Given this list of marker genes PCLAF, HMGN2, AURKB, BIRC5, HMGA1, ANP32E, KPNA2, DUT, GAPDH, CDK1, H4C3, SMC4, ZWINT, TUBA1B, HMGB2, SNRPF, RAN, NUSAP1, RANBP1, LDHA (lactate dehydrogenase A), SNRPD1, CKS1B, STMN1, CENPM, PTTG1, ANP32B, H2AZ2, UBE2C, MCM7, MKI67, ENO1, CDKN3, TK1 (NCBI Gene Id 7083), PCNA, DEK (NCBI Gene Id 7913), TUBB, TUBB4B, H2AZ1, TYMS, CKS2, TOP2A, HMGB1, RRM2, PKM, TCL1A, IRAG2, SLC25A5, here is a description of the gene set: Genes upregulated in subsets of cells of a given type within various tumors from publication Gavish A, Tyler M, Greenwald AC, Hoefflin R, Simkin D, Tschernichovsky R, Galili Darnell N, Somech E, Barbolin C, Antman T, Kovarsky D, Barrett T, Gonzalez Castro LN, Halder D, Chanoch-Myers R, Laffy J, Mints M, Wider A, Tal R, Spitzer A, Hara T, Raitses-Gurevich M, Stossel C, Golan T, Tirosh A, Suvà ML, Puram SV, Tirosh I (PMID 37258682) In this study, an extensive analysis was conducted to define meta-programs (MPs) capturing intra-tumor heterogeneity across a spectrum of tumor types. The approach utilized non-negative matrix factorization (NMF) to analyze each cell type separately within individual tumor samples. This involved the analysis of malignant cells, macrophages, fibroblasts, endothelial cells, epithelial cells, T-cells, and B-cells. NMF was executed with varying parameter values (K=4, 5, 6, 7, 8, 9), thereby generating 39 programs for each cell type per sample. Each NMF program was summarized by the top genes based on NMF coefficients.\nRobust MPs were then delineated for each cell type using a set of stringent criteria, including recurrence within the same tumor, similarity to programs in other tumors, and non-redundancy within a tumor. Subsequently, these robust NMF programs were clustered (per cell type) based on Jaccard similarity, leading to the identification of MPs associated with each cell type.\nTo enhance the quality of the MPs, a refinement steps were undertaken, involving the removal of MPs suspected of reflecting low-quality data (with an overrepresentation of ribosomal proteins or mitochondrial-encoded genes), single-study inclusion, or similarity to miss-annotated cell types. studied in species Homo sapiens Human Gene Set: GAVISH_3CA_METAPROGRAM_B_CELLS_CELL_CYCLE